Given this list of marker genes Egfr, Twist1, Srf, Sox11, Jun, Grhl3, Hdac1, Hdac2, Map3k1, Inhba, Tfap2a, Osr2, Stra6, Prickle1, Sos1, Kmt2c, here is a description of the gene set: The progression of the eyelid in a camera-type eye from its formation to the mature state. The eyelid is a membranous cover that helps protect and lubricate the eye. Mouse Gene Set: GOBP_EYELID_DEVELOPMENT_IN_CAMERA_TYPE_EYE studied in species Mus musculus